The following is a description of a gene set: Mouse Gene Set: GOBP_REGULATION_OF_TRNA_STABILITY Any process that modulates the propensity of transfer RNA (tRNA) molecules to degradation. Includes processes that both stabilize and destabilize tRNAs. species: Mus musculus, and this is the list of marker genes: Trdmt1, Slfn2, Mettl1, Ang, Nsun2